The following is a description of a gene set: A deep defect in the esophageal, gastric, duodenal or intestinal wall involving the entire mucosal thickness and penetrating through the muscularis mucosae. Human Gene Set: HP_GASTROINTESTINAL_ULCER Gastrointestinal ulcer studied in species Homo sapiens, and this is the list of marker genes: CISD2, SLC9A3, STX1A, WFS1 (wolframin ER transmembrane glycoprotein), SYK (NCBI Gene Id 6850), SRSF2, TTC7A, XIAP, MEN1 (menin 1), STAT3, ASXL1, MMP1, TNFAIP3, XYLT2, KIT, MSR1, HPGD, SLCO2A1, PLG, BUD23, CDKN2C, ARID1B, GTF2I, LIMK1, CDKN1A, METTL27, RFC2, EP300, DNAJC30 (NCBI Gene Id 84277), ASCC1 (NCBI Gene Id 51008), CDKN1B, TBL2, NCF1, CDKN2B, GTF2IRD2, GTF2IRD1, FKBP6, EIF4H, VPS37D, CDC73, TMEM270, CTHRC1, PLA2G4A, ELN (NCBI Gene Id 2006), COL7A1, GBA1, GNA11, CLIP2, TET2, AP2S1, PI4KA, BAZ1B